The following is a description of a gene set: Reactome Pathway: GTP hydrolysis and joining of the 60S ribosomal subunit studied in species Homo sapiens Hydrolysis of eIF2-GTP occurs after the Met-tRNAi has recognized the AUG. This reaction is catalyzed by eIF5 (or eIF5B) and is thought to cause dissociation of all other initiation factors and allow joining of the large 60S ribosomal subunit. The 60S subunit joins - a reaction catalyzed by eIF5 or eIF5B - resulting in a translation-competent 80S ribosome. Following 60S subunit joining, eIF5B hydrolyzes its GTP and is released from the 80S ribosome, which is now ready to start elongating the polypeptide chain. part of: Cap-dependent Translation Initiation, and this is the list of marker genes: RPS15A, RPL13A, RPL35A, EIF4E, RPL37A, RPL10A, RPS4X, EIF5, RPL18A, EIF3G, RPS11 (ribosomal protein S11), EIF3E, RPL23, RPL4, RPL29, RPS6, EIF3L, RPS14, RPS5, RPL30, EIF4H, RPL36AL, RPL12, EIF3J, RPS26, RPL3L, RPL26L1, RPL31, UBA52, EIF3K, RPL37, RPL27A, RPL39L, RPS27, RPS3, RPL36A, RPS4Y2, EIF4G1, RPL32, RPLP1, 18S rRNA, RPL23A, RPL11, 28S rRNA, RPS4Y1, RPSA, RPL35, RPL6, RPL28, RPL9, RPL41, RPS29, RPL39, RPS21, RPL34, EIF2S2, 5S rRNA, EIF4B, EIF4A1, RPS27A, RPL8, EIF3F, RPS24, RPL3, RPL5, RPS9 (NCBI Gene Id 6203), RPL21, RPL22, RPL17, RPS17, RPLP2, RPL7A, RPS25, EIF2S1, RPS13, EIF3B, RPS18, RPS27L, RPL27, 5.8S rRNA, EIF1AX, RPL15, EIF3C, RPL10, EIF3A, RPS20, EIF3M, RPS7, RPS19, RPS28, RPL10L, RPS2, RPL38 (ribosomal protein L38), FAU (NCBI Gene Id 55430), EIF3I, EIF3D, RPLP0, RPL22L1, RPL24, RPL7, EIF4A2, EIF5B, EIF2S3, RPS23, RPL19, EIF3H, RPL26, RPL36, RPL14, RPS10, RPS3A (ribosomal protein S3A), RPS8, RPS16, RPL18, RPL13, RPS12, RPS15